Given this list of marker genes RHBG, RHCG, GLUL, OTC, RHCE, RHD (Rh blood group D antigen), RHAG, here is a description of the gene set: species: Homo sapiens Any biological process involved in the maintenance of an internal steady state of ammonium. Human Gene Set: GOBP_AMMONIUM_HOMEOSTASIS